The following is a description of a gene set: Human Gene Set: GSE36392_TYPE_2_MYELOID_VS_NEUTROPHIL_IL25_TREATED_LUNG_UP Many symptoms associated with allergic asthma result from the sequelae of type 2 inflammation. Interleukin (IL)-25 promotes type 2 inflammatory responses, and T2M cells represent an IL-4 and IL-13 producing granulocytic IL-25 responsive population. We used microarrays to characterize the gene expression profile of T2M cells, and compared T2M cells to other inflammatory subsets (eosinophils, neutrophils, and macrophages) in the lungs of mice with IL-25-induced pulmonary inflammation. from publication Petersen BC, Budelsky AL, Baptist AP, Schaller MA, Lukacs NW (PMID 22543263) Genes up-regulated in comparison of type 2 myeloid (T2M) cells treated with IL25 versus neutrophils treated with IL25. species: Homo sapiens, and this is the list of marker genes: COL6A1, NEU1, SIGLEC10, GADD45A, DSP, ABCB4, RAB27A, SH3KBP1, ATP8B1, INMT, CEBPB, ANKRD33B, ARHGAP4, GFOD1, RAP1GAP2, CYFIP1, KDM5B, EBI3, FGD4, ZNF579, SLCO4C1, PIGV, LTA4H, PCDH11X, CHRNA6, RASL10B, SOCS1, ADM, DEGS1, AMPD3 (adenosine monophosphate deaminase 3), CHRNB1, EGLN3, PSTPIP2, APOBR, LDB2, WNT8A, CARNS1, BCL2L10 (BCL2 like 10), TNIK, LPIN1, DLGAP4, SEMA7A, H1-8 (H1.8 linker histone), KLHDC3, MTTP, ZNRF1, CALCRL, SNAP47, KIT, SPARC, IGF1R, TRIM56 (tripartite motif containing 56), HCK, ABCC5, CNTD1, ZNF473, CDKN2B (NCBI Gene Id 1030), HELZ2, PCDHB5 (protocadherin beta 5), BCL2L15, CTNNAL1, MMD (NCBI Gene Id 23531), FMO1, NSD3, UNC45A, PCYT1A, CD69, TOP3B, SMARCD2, PRKCQ, PTPN21 (NCBI Gene Id 11099), TTC7B, RALGAPA1, FHL2 (four and a half LIM domains 2), DGKZ, ZFAND4, ALOX15, ERO1A, ASPA, PER2, TCN2, LYST, FFAR2, LRP11, HTR4, SLC18A2, TRMU, ACTN1, TSPAN9, TREML2, PLEKHA2, KLHL6, LRWD1, GATA2, SF3A2, IL1A, OGT, SMAD3, SOCS7, SLC11A1, CAVIN2, CPD, ATP6V0B, PABIR1, RBL2, BANK1, DENND4A, CTSE, ARSG, HSH2D, CYLD (NCBI Gene Id 8010), SLC2A3, PLD1, TNK2, BIRC3, ADGRG6, RAPGEF6, FGD3, ACP3, IL1RL1, CCNG2, SPINT2, ARMCX4, IPCEF1, STX11, FOSL1, EHD1, PYGL, SLC16A9, GIT2, ROBO3, TM4SF1, F2RL2, RASGEF1A, TIRAP, CXCR3, GTPBP2, MARVELD1, C1QTNF12, COL4A2, SRPK2, PITPNM1, ALAS1, ROBO4 (roundabout guidance receptor 4), EPX, LRSAM1, CTU2, NCOA4 (nuclear receptor coactivator 4, NCBI Gene Id 8031), CLSTN1 (NCBI Gene Id 22883), SLCO2A1, HSPA12B, HCAR2, F2R (coagulation factor II thrombin receptor), BSDC1, GSK3A, TMEM170A (transmembrane protein 170A), NCKAP1, SKIL, GPI, CREB3L1, FGD5, MRGPRE, FAM13B, PAXBP1, EPHB4, ZEB1, CCDC17, DMXL2, CHST15, PHF21A, LIMD2, MCL1, SCNN1A, BASP1, CHST13, CLU, P2RY14, MYLK, ARHGEF2, TMCC1, TMEM154, TTK, LASP1, HIC1, CASD1, COX17, CDO1, RASSF5, BRD8, CYP2C8 (NCBI Gene Id 1558), GPR153, IL9R, DACH1, FGFR1, BTG1, VCL, CA4, CAMKK1, ZNF292, RAB6B